Given this list of marker genes IRGM, CLU, SNF8, SNX16, LAPTM5, VPS53, TSG101, MVB12A, VPS37C, GGA3, TNFAIP3, AP4M1, VPS37D, VPS37B, AP3D1, ZFYVE16, VPS37A, M6PR, GNPTG, HSPA8, VPS28, SMURF1, VPS36, NEDD4, VPS13C, GNPTAB, NDP, SQSTM1, WASH3P, VPS13A, VPS41, PTPN23, UBAP1, STAM2, PIK3R4, VPS4A, MON1B, RAB7A, STAM, ATG14, MON1A, SORT1, AP3M1, VPS13D, VPS8, PIK3C3 (NCBI Gene Id 5289), BECN1 (beclin 1), VPS25, MVB12B, SORL1, VPS54, NAGPA, HGS, SCARB2, LAMP2, AP3B1, GCC2, NCOA4, here is a description of the gene set: species: Homo sapiens The directed movement of a protein to a specific location in a vacuole. Human Gene Set: GOBP_ESTABLISHMENT_OF_PROTEIN_LOCALIZATION_TO_VACUOLE